Given this list of marker genes HPS3, TUBA1A, WDR45, CRLF1, KCTD12, STX16, CTLA4, RPL18A, RCSD1, PLEKHB2, TLN1, TSC1, D2HGDH, NPC1, SF3B1, RPL22L1 (NCBI Gene Id 553116), RNF138, WDR44, C15orf39, PHF21A, CDT1, ZNF395, INTS6L, WSB1, ACTRT3, DYNLT3, TOB2, ZNF692, GIGYF1, REST, MAGEF1, IKZF5, HPSE, BHLHA15, GRIA3, RNF167, LCOR, MAP4K3, MTA3, IPCEF1, DVL1, CELF2, CD3G, SKI, SSH2, BRAP, ZNF326, TTC19, TUG1 (taurine up-regulated 1), RAB30, LENG8, ZMYND11, GMIP, DUSP5, ADAM19, BCL10, RNF215, SCAND1, SYK, DUSP6, C15orf61, MYH9, SRSF6, CLINT1, SARAF, CUX1, PIAS1, COQ10A, ACKR2, WBP1, SLC66A2, ERP29 (NCBI Gene Id 10961), ZBTB43, DOCK11, RELB, PIKFYVE, NHLRC2, ITPKC, BANK1 (NCBI Gene Id 55024), MAP1LC3A, TPRA1, CACUL1, GRAP2, MXD4, RAB33B, GNAQ (G protein subunit alpha q), UNC119, SBNO2, AFF3, INPP5K, AVL9, CSK, HLA-DOB, SENP6, ADCY7, H3-5, GNGT2, IL1RL1, SIPA1L1, HIGD2A, CROT, ATP1B1, IDS, CPEB4, BCL7B, TAB2, MYO6, HERC4, VPREB3, IL6ST, KDM5A, FGFR1OP2, SESN3, CEACAM21, TPST2, YIPF3, LMBR1L, PPP1CB, CAB39, E4F1, PWWP2A, HERPUD2, PCNX1, PSTPIP1, PLD3, CEPT1, MYO1E (myosin IE), PITPNC1 (phosphatidylinositol transfer protein cytoplasmic 1), PPP3CA, MAST3, CHD6, RABGEF1, CD2, CYTH1, MYO18A, CNOT8, GCOM1, CEP57, CYRIB, NCOA6, NRM, THAP6, VGLL4 (vestigial like family member 4), ARHGAP24, FASLG, PLGRKT, CDS2, FAM8A1, BSDC1, CDKN2AIP, NRROS, CCNI, ARMCX5, RPRD2, UBXN2A, BCAS3, AK8, MACIR (macrophage immunometabolism regulator), GRAMD2B, CBFA2T2, COBLL1, IL6R (interleukin 6 receptor), RAD18, SH3TC1, PRKX, SLK, TTLL3, CPSF7, SDHAF1, TGFB1, REXO1, STRN3, TAOK3, TTC7A, CAST, DFFA, ARHGAP15, DICER1, MTMR12, CRTC3, SKAP1, FGD6, NCF2, CD1D, TFEB, SGMS1, ZNF839, CYBB, FYN, ZMIZ1, P2RX7, EIF1, PLCG1, POU5F2 (NCBI Gene Id 134187), SFT2D1, AZI2, SF1, HCFC1R1, UBL3, SYNRG, here is a description of the gene set: The genome of vertebrates contains endogenous retroviruses (ERVs) that have resulted from ancestral infections by exogenous retroviruses. ERVs are germline encoded, transmitted in a Mendelian fashion and account for about 8% of the human and 9.9% of the murine genome, respectively1, 2. By spontaneous activation and reintegration ERVs may cause insertional mutagenesis and thus participate in the process of malignant transformation or progression of tumor growth3, 4. However, if the innate immune system is able to recognize and control ERVs has not yet been elucidated. Here we report that, in vitro, nucleic-acid sensing TLRs on dendritic cells are activated by retroviral RNA and DNA from infected cells in vitro. Infection of TLR competent wild type mice with murine leukemia virus (MuLV)-like ERV isolates results in non-canonical gene upregulation, independent of type I IFN. In vivo, TLR3, -7 and -9 triple deficient mice (TLR379-/-) and mice with non functional TLR3, 7 and 9 signaling due to a mutation in UNC93B develop spontaneous ERV-induced viremia. More importantly, in TLR379-/- mice ERV-induced viremia correlates with acute T cell lymphoblastic leukemia (T-ALL). Multiple independent TLR379-/- T cell leukemia lines produce infectious MuLV of endogenous origin. These cell lines display de novo retroviral integration into the Nup214 or Notch1 gene locus leading to gene dysregulation that is reminiscent of aberrant Nup214 and Notch1 expression in human T-ALLs5. Overall, our results demonstrate that in addition to their role in innate immune defense against exogenous pathogens, TLR3,-7, and -9 may be essential for the control of endogenous retroviral mediated T-cell lymphomagenesis. Genes up-regulated in splenocytes: control versus infected with Baki-1 MuLV virus. studied in species Homo sapiens Human Gene Set: GSE24671_CTRL_VS_BAKIMULC_INFECTED_MOUSE_SPLENOCYTES_UP from publication Yu P, Lübben W, Slomka H, Gebler J, Konert M, Cai C, Neubrandt L, Prazeres da Costa O, Paul S, Dehnert S, Döhne K, Thanisch M, Storsberg S, Wiegand L, Kaufmann A, Nain M, Quintanilla-Martinez L, Bettio S, Schnierle B, Kolesnikova L, Becker S, Schnare M, Bauer S (PMID 23142781)